The following is a description of a gene set: This event has been computationally inferred from an event that has been demonstrated in another species.<p>The inference is based on the homology mapping from PANTHER. Briefly, reactions for which all involved PhysicalEntities (in input, output and catalyst) have a mapped orthologue/paralogue (for complexes at least 75% of components must have a mapping) are inferred to the other species. Reactome Pathway: Signaling by MST1 species: Mus musculus electronically inferred by orthology from the curated human pathway part of: Signaling by Receptor Tyrosine Kinases, and this is the list of marker genes: Mst1 (macrophage stimulating 1 (hepatocyte growth factor-like)), Spint1, Hpn